Given this list of marker genes CD36, HLA-A, PDGFRB, BAD, APRT, CCN2, RHOG, KRT7, EFNB3, FOS, FASTK, ANK1, PLA2G6, VEGFC, MMP11, BMP4, HBEGF, CDKN2C, JUNB, TIMP3, GLRX, BSG, KRT14, CD8B, QSOX1, CAV2, KRT19, IGFBP2, SOD3, MMP19, BMP6, NGFR, CASP9, TIMP2, TGFB1, FOSB, TP53I11, ITGA3, TRIP6, CD9, VTN, MMP13, COL11A2, COL1A2, CGB3, LUM, ARHGDIB, ITGA7, JUP, FBN2, here is a description of the gene set: Cancer related genes up-regulated in any of four hepatoma cell lines following 24 h treatment with TSA. OBJECTIVE: Histone deacetylase (HDAC) inhibitors have been reported to induce cell growth arrest, apoptosis and differentiation in tumor cells. The effect of the HDAC inhibitor, trichostatin A (TSA), on hepatoma cells, however, has not been well studied. In this study, we examined cell viability and gene expression profile in hepatoma cell lines treated with TSA. METHODS: To study cell growth inhibition and induction of apoptosis by TSA on human hepatoma cell lines including HuH7, Hep3B, HepG2, and PLC/PRF/5, cells were treated with TSA at various concentrations and analyzed by the 3-(4, 5-dimethyl-2-thiazolyl)-2H-tetrazolium bromide (MTT) and TUNEL assays, respectively. Changes in gene expression profile after exposure to TSA were assessed using a cDNA microarray consisting of 557 distinct cDNA of cancer-related genes. The levels of acetylated histones were examined by the chromatin immunoprecipitation (ChIP) assay using anti-acetylated histone H3 or H4 antibody. RESULTS: The MTT assay demonstrated that TSA showed cell growth inhibition not only in a concentration-dependent but also a time-dependent manner on all cell lines studied. The TUNEL assay also revealed the potential of TSA to induce apoptosis. The microarray analysis revealed that genes including collagen type 1, alpha2 (COL1A2), insulin-like growth factor binding protein 2 (IGFBP2), integrin, alpha7 (ITGA7), basigin (BSG), quiescin Q6 (QSCN6), superoxide dismutase 3, extracellular (SOD3), nerve growth factor receptor (NGFR), and p53-induced protein (PIG11) exhibited substantial induction (ratio >2.0) after TSA treatment in multiple cell lines. ChIP assay, in general, showed a good correlation between the expression level of mRNA and levels of acetylated histones in these upregulated genes. CONCLUSIONS: This study showed cell growth inhibition and the gene expression profile in hepatoma cell lines exposed to TSA. The alteration in levels of acetylated histones was closely associated with expression of specific cancer-related genes in hepatoma cells. Human Gene Set: CHIBA_RESPONSE_TO_TSA_UP species: Homo sapiens from publication Chiba T, Yokosuka O, Fukai K, Kojima H, Tada M, Arai M, Imazeki F, Saisho H (PMID 15452378)